Given this list of marker genes Klhl4, Brcc3dc, Gan, Pef1, Rnf40, Appbp2, Klhl20, Spop, Fbxo42, Brca1, Spsb3, Pdcd6, Phc2, Armc8, Zswim8, Rmnd5a, Dtl, Klhl1, Spsb2, Pramel30, Cdc23, Amfr, Med17, Anapc13, Klhl3 (kelch-like 3), Prkn, Fam8a1, Ube3d, Fbh1, Klhl29, Rad51, Traf7, Cbx6, Fbxl16, Pramel29, Dcaf4, Pramel17, Bmi1, Pcgf3, Bard1 (BRCA1 associated RING domain 1), Fbxw8, Rmnd5b, Klhl30, Rnf144b, Fbxo31, Lztr1, Zyg11b, Oog3, Brcc3, Klhl28, Anapc15-ps, Asb17, Cdkn1b, Cdc27, Ercc8, Cblc, Kctd13, Klhdc10, Pramel28, Fbxo9, Maea, Dcun1d3, Dmac2, Kctd5 (NCBI Gene Id 69259), Cul1, Gm13040, Wdr26, Med20, Pcgf1 (polycomb group ring finger 1), Pramel45, Tmem183a, Neurl2, Rnf11, Pramel46, Pramel12, Spsb1, Fbxo8, Pramel41, Med18, Dcaf8, Rnf14, Glmn, Rnf8, Ube2s, Pramel14, Cdc16, Arih1, Klhl11, Fem1b, Vcp, Fbxw5, Dcaf17, Klhl2, Fbxo45, Babam2, Fem1a, Fem1al, Otulin, Ddb2, Zyg11a, Fbxl4, Siah1a, Pramel61, Skp1, Pramel27, Pramel15 (PRAME like 15), Ranbp10, Fbxl12, Anapc7, Ubr3, Fbxw7, Eloc, Ubr2, Rchy1, Dcaf10, Samd7, Fbxl13, Plaa, Klhl35, Ambra1 (autophagy/beclin 1 regulator 1), Spopl, Cbx8, Ube2b, Cand1, Anapc10, Gid4, Med31, Brap, Vhl, Dyrk2, Pramel57, Fbxl5, Anapc15, Pramel40, Ubac1, Pramel60, Abtb1, Fbxo39, Fbxl9, Tes3-ps, Klhl10, Pramel19, Topors, Pramel13, Dcaf12l2, Asb4, Pramel25, Commd1, Med23, Rnf217, Dcaf1, Asb1, Pramel44, Ranbp9, Fbxw11, Cbx4, Ankrd9, Oog2, Enc1, Fbxo15, Fbxo7 (NCBI Gene Id 97657), Rbx1, Asb2, Dcaf15, Dcun1d4, Rnf7, Pramel48, Pramel20, Ubr1, Klhl21, Cbx2, Mib2, Pramel1, Zswim6, Kbtbd12, Med6, Klhl5, Fbxo44, Pramel32, Cdk8, Rnf31, Kbtbd8, Kctd17, Pramel16, Fbxw4, Med30, Dda1, Socs7, Asb11, Pcgf5, Pramel50, Pramel54, Klhl8, Oog4, Megf8, Fbxl15, Cacybp, Skp2, Klhl24, Rad18, Med27, Pcgf6, Klhl38, Ube4b, Klhl40, Pramex1, Pramel51, Pramel47, Dcaf5, Fbxl2, Klhl17, Mad2l2, Dcun1d5, Sel1l, Anapc4, Pramel7, Pramel31, Anapc5, Ube2srt, Gpr37, Ube2j2, Tnfaip1, Kbtbd3, Fbxo3, Fbxl22, Med24, Med12 (mediator complex subunit 12), Med1, Wdr77, Pramel21, Med11, Dcaf12, Pnkp, Klhl6, Ube2v1, Klhl22, Klhl18, Arih2, Rnf168, Smurf2, Rnf19b (ring finger protein 19B), Anapc2, Fbxo48, Phc3, Usp47, Klhl23, Pramel26, Ccnc, Dcaf12l1, Depdc5, Kbtbd7, Pramel56, Amn1, Fbxl17, Stub1, Ccnf, Pramel6, Cul4a, Cul5, Hdac6, Klhl42, Sharpin, Cul4b, Det1, Socs2, Zer1, Cul7, Nedd4, Fbxl18, Rnf7l, Mkln1, Kbtbd2, Fbxo17, Fbxo6, Pramel11, Fbxo2, Ube2a, Kctd10, Traf2, Cul3, Fbxl19, Fbxl6, Cbx7, Bcor, Klhdc3, Med7, Klhdc2, Aurkaip1, Fbxo32, Dcaf6, Cop1, Crbn, Klhl25, Itch, Mgrn1, Syvn1, Asb9, Phc1, Fbxl7, Dcaf11, Anapc16, Ypel5, Dcaf8l, Klhl9, Gid8, Lrrc75a, Pramel24, Klhl15, Asb12, Kctd2, Pramel55, Med10, Klhl12, Zswim4, Pramel23, Btrc, Ube2c, Ube2n, Pramel36, Ube4a, Ube2d1, Pramel34, Pramel49, Klhl13, Pramel35, Pramel37, Fbxo27, Rbck1, Ipp, Fbxo24, Ddb1, Trim63, Klhdc1, Elob, Kbtbd6, Fbxo4, Ring1 (ring finger protein 1), Fbxl14, Katna1, Klhl41, Rnf20, Cdc20b, Cks1brt, Cul9, Trpc4ap, Med21, Pramel18, Cdc20, Pramel59, Pramel33, Daw1, Cul2, Pcgf2, Pramel39-ps, Samd11, Fbxl3, Fbxl21, Ankib1, Pramel38, Pramel5, Keap1, Dcaf7, Fzr1, Pramel22, Zswim5, Anapc1, Rnf144a, Fbxo25 (NCBI Gene Id 66822), Rnf2 (NCBI Gene Id 98537), Fem1c, Pramel42, Ube2e1, Cks2, Ube2d2a, Klhl7, Ivns1abp, Fbxl20, Cks1b, Trim21, Wdtc1, Elobl, Pramel53, Ccin, Rbx1-ps, Spsb4, Dcaf13, Cdc26, Oog1, Rnf19a, Brca2, Nccrp1, Pcmtd1, Ikbkg, Anapc11, Dcun1d2, Dcun1d1, Atg3, Pramel43, here is a description of the gene set: Mouse Gene Set: GOCC_UBIQUITIN_LIGASE_COMPLEX A protein complex that includes a ubiquitin-protein ligase and enables ubiquitin protein ligase activity. The complex also contains other proteins that may confer substrate specificity on the complex. studied in species Mus musculus